The following is a description of a gene set: studied in species Homo sapiens Human Gene Set: GOCC_KINETOCHORE_MICROTUBULE Any of the spindle microtubules that attach to the kinetochores of chromosomes by their plus ends, and maneuver the chromosomes during mitotic or meiotic chromosome segregation., and this is the list of marker genes: CHMP2A, CHMP6, CHMP3, BBLN, ZW10 (zw10 kinetochore protein), RAB11A, CHMP5, CLASP2, CHMP4B, KNTC1 (NCBI Gene Id 9735), ZWILCH, CENPE, CHMP1B, CHMP1A, CHMP2B, CHMP4BP1 (charged multivesicular body protein 4B pseudogene 1), KIF18A, CHMP4C, CLASP1 (NCBI Gene Id 23332), CHMP7, CHMP4A